The following is a description of a gene set: Genes predicted to be targets of miRBase v22 microRNA mmu_miR_1892 in miRDB v6.0 with MirTarget v4 prediction scores > 80 (high confidence targets). studied in species Mus musculus Mouse Gene Set: MIR_1892 from publication Chen Y, Wang X (PMID 31504780), and this is the list of marker genes: Nos1, Tfap4, Tom1, Foxp3, Col1a1, Xkr4, Lima1, Ndc80, Larp4, Epsti1, Arhgap33, Fzd8, Xpr1, Patz1, Nexn, Dcun1d3, Ppp1r3b, Slc7a2, Septin3, Abcb7, Ptpra, Dnajc3, Arhgap15, Dhdds, Sec61a2, Dag1, Shisal1, Slamf6 (NCBI Gene Id 80894), Yy1, Dtd2, Alox12e, Elavl3, St8sia3 (ST8 alpha-N-acetyl-neuraminide alpha-2,8-sialyltransferase 3), Zfp606, 9330159F19Rik, Pcnx1, Jazf1, Pik3ca, Clip3, Gpr119, Lyrm7, Flrt2, Rxrg, Pvr, Cfap90, Slc25a23, Cbx6, Zbtb39, Bnc1, Fam117b, Znrf3, Masp1, Kpna1, Zfhx4, Brms1l, Zfp277, H2-M2 (NCBI Gene Id 14990), Zfp385a, Slc10a1, Spry4, Dlk1, Ttc21b, Cdh2, Znrf2, Stxbp5l, Sp1, Tyrobp, 4930513O06Rik, Abhd6, AI593442, Elk1, Ptprr, Prkcb, Rtp3, Igf2, Slc1a2, Tram1, Fstl3, Acer3, Rtbdn, Ppp1r9b, Thbs1, Josd1, Fam221a, Ms4a4c, Synj2bp, Luc7l3